Given this list of marker genes Uck2, Uck1, Uckl1, Upp2, Upp1, Cda, here is a description of the gene set: Any process that generates a pyrimidine-containing compound, a nucleobase, nucleoside, nucleotide or nucleic acid that contains a pyrimidine base, from derivatives of them without de novo synthesis. Mouse Gene Set: GOBP_PYRIMIDINE_CONTAINING_COMPOUND_SALVAGE studied in species Mus musculus